The following is a description of a gene set: Mouse Gene Set: GOBP_RIG_I_SIGNALING_PATHWAY species: Mus musculus The series of molecular signals initiated by the binding ssRNA or dsRNA from another organism to the cytoplasmic pattern recognition receptor (PRR) RIG-1 (also known as DDX58). RIG-I detects RNA synthesized during viral replication or shed by non-viral pathogens, and triggers a signaling pathway to protect the host against infection, for example by inducing the expression of cytokines., and this is the list of marker genes: C1qbp, Nlrx1, Phb2, Oas3 (2'-5' oligoadenylate synthetase 3), Phb1, Pum1, Rnf125, Lsm14a, Ufd1, Rnf135, Pum2, Zc3hav1, Nploc4, Clpb, Dhx58, Ddx60, Gpatch3, Usp17le, Zcchc3, Sec14l1, Mavs, Nop53, Ankrd17, Oasl1 (NCBI Gene Id 231655), Rigi, Usp15, Trim15